The following is a description of a gene set: Delayed menarche species: Homo sapiens First period after the age of 15 years. Human Gene Set: HP_DELAYED_MENARCHE, and this is the list of marker genes: RASA2, NRAS, SOS1, RRAS2, STUB1, SPRED2, GHR, LMNA, RRAS, HROB, KRAS, MRAS, RAF1, ALMS1, FSHB, ZMPSTE24, RIT1, SLC25A13, SOS2, PEX10, LZTR1, CBL, DNM1L, PTPN11